The following is a description of a gene set: Mouse Gene Set: GOMF_TOXIC_SUBSTANCE_BINDING species: Mus musculus Binding to a toxic substance, a poisonous substance that causes damage to biological systems., and this is the list of marker genes: Alb, Gucy2c, Nefh, Nefm, Ahr, Adgrl1, Gstp2, Gstp1, Phax, Gsta4, Ephx2, A4galt, Tmem181a, Chrna7, Ass1